Given this list of marker genes MYOD1, PPP2R3B, EGF, TTN-AS1, PEG10, CAVIN4, COX6A2 (cytochrome c oxidase subunit 6A2), MYH3, MYREM, COX7A1, HSPB7, TRIM54, CMYA5, LSMEM2, AGL, ACTA1, PRKACA, ENSG00000227531, SMPX, SRPK3, KLHL21 (kelch like family member 21), CACNA1S, FLNC, MAMSTR, MRLN (NCBI Gene Id 100509305), DUSP13B, TMEM38A, LRRC52-AS1, TCEANC2, C4orf46, TNNI1, ADPRHL1, FITM1, ZNF593, ENSG00000234352, PPP1R3A, HSPB6, RAMP1, NEB, SMTNL2, PACSIN3, TXLNB, DNAJB5, CKM, LINC00616, DOK7, STUM, BAK1, ACTN2, ITGB6, MYOM2, STYXL2, MYOM1, CDH15, CACNG1, MYBPC1, NMRK2, HSPB2 (heat shock protein family B (small) member 2), MIR133A1HG, CORO6, ATP1B4, CASQ2, GADL1, FSD2, TTN, STAC3, TNNT2, MYL6B, KLHL41, NRXN1-DT, SRL, RUNDC3A-AS1, ADAM7-AS1 (ADAM7, ADAMDEC1 and ADAM28 antisense RNA 1), LANCL1-AS1, MYOG, TCEAL7, FZD10, LMOD3, LINC01479, TRIM55, POLR1F, LINC01405, CSRP3, SGCA, DUSP26, MYL2, TRPC6, ALX4, CFL2, SMYD1, MYL4, MB, HJV, SATB2-AS1, ATP2A1, ENO3, TRIM72 (NCBI Gene Id 493829), STARD13-IT1, TRDN, TPM1, TNNT1, IL32, CAV3, GPC4, MYH8, MYOT, MYL11, SYNPO2L, LINC01497, EME1, LINC02308, CARNS1, XIRP1, MYBPH, NEXN, XIRP2, TNNC2, TRIM32 (tripartite motif containing 32), TNNI2, ADAM7-AS2, CHRNB1, NES, LAMTOR5, EIF5-DT, TRIB3, NPSR1-AS1, MYL1, TNNC1, TNNT3, APOBEC2, KCNE5, UNC45B, VGLL3 (NCBI Gene Id 51159), RAPSN, MYH2, SBDS, CACNG6, PLK5, MYOZ2, AK1, EIF1AY, RFPL2, CHRND, GAMT, MEG9, CHRNA1, ACTC1, ASB5 (NCBI Gene Id 140458), TMEM182, ENSG00000265751, SLN, TBX1, KLHL31, MLIP, TPM2, LRRC38, MYH7, ADAMTS8, IL17B, GAL3ST1, FABP3, BOK, NPM3, FBXO32, H2BC21 (NCBI Gene Id 8349), LDB3, MYH15, DES, MYF6, CDH13-AS2, MYL3, MYOM3, here is a description of the gene set: species: Homo sapiens Human Gene Set: DESCARTES_FETAL_EYE_SKELETAL_MUSCLE_CELLS from publication Cao J, O'Day DR, Pliner HA, Kingsley PD, Deng M, Daza RM, Zager MA, Aldinger KA, Blecher-Gonen R, Zhang F, Spielmann M, Palis J, Doherty D, Steemers FJ, Glass IA, Trapnell C, Shendure J (PMID 33184181) Marker genes curated from the annotated cluster as represented in the Descartes Human Gene Expression During Development database. The gene expression program underlying the specification of human cell types is of fundamental interest. The study authors generated human cell atlases of gene expression and chromatin accessibility in fetal tissues. For gene expression, the study authors applied three-level combinatorial indexing to >110 samples representing 15 organs, ultimately profiling ~4 million single cells. The study authors leveraged the literature and other atlases to identify and annotate hundreds of cell types and subtypes, both within and across tissues. Our analyses focused on organ-specific specializations of broadly distributed cell types (such as blood, endothelial, and epithelial), sites of fetal erythropoiesis (which notably included the adrenal gland), and integration with mouse developmental atlases (such as conserved specification of blood cells). These data represent a rich resource for the exploration of in vivo human gene expression in diverse tissues and cell types.